Given this list of marker genes Ebag9, A830018L16Rik, Sesn1, Sppl2a, Tbc1d8b, Tex30, Aspn, Nup58, Nt5c3, Cxcl13, 5330438D12Rik, Ube2v2, Eif2s2, Ssr1, Slc7a3, Gimap5, Marchf5, C1galt1c1, Sp110, Lemd3, Ly96, Fgfbp3, Lrrc75b, Trem2, Cstdc4, Mterf2, Myo1c, Acyp2, B3galnt1, Tmem126a, Atp6ap2, Slc26a11, Gin1, Sparcl1, Ubqln2, Ptgs1, Slc35b3, Flvcr1, Pias2, Amy1, Dvl1, Fgf18, Orc6, Zfp185, Plekhs1, Casp12, Klf9, Rps6kb1, Tmem35a, Cpa3, Hnrnpdl, Arrb2, Syncrip, Mbd1, Cav1, Pik3r3, Paip1, B2m, Slc25a12, Hnrnpll, Ncl, Fndc1 (NCBI Gene Id 68807), Ric8a, Sema3g, Arl13b, Smg7, Depdc1a, Acat1, Mmrn1, Tipin, Zfp973, Tle1, Nab1 (NCBI Gene Id 17936), Sbds, Cavin2, Sdcbp, Cnih1, Pdcd10, Adamts2, Ms4a6d, Tac1, Nmb, Ifrd1, Agl, Ktn1, P4ha2, Spink2, Ppp4r1l-ps, Dixdc1, Slc35a5, Colec12, Gfpt1, Agbl3, Fap, Hdc, Slc1a3, Wfdc18, Usp16, Vegfd, Psmc6, Trappc2b, Zfp639, Pfas, Tyrobp, Mpc1, Fabp4, Vip, Ndfip2, Atrnl1, Sfxn3, Slc38a9, BC050972, Scyl3, Ptprb, Qpct, Spopl, Med21, Lhx6, Calca, Ramac, Rnf11, Serinc3, Ccdc32, Gclc, Dock11, Plgrkt, Gpr182, Pten, Hprt1, Smurf2, Cd300c2, Cftr, Smpdl3a, Ctso, Zfp318, Cast, Rnf130, Clec14a, Lrrc17, Ms4a6b, Casp4, Aoc3, Spryd7, Prkd3, Slc16a3, Eif2ak2, Prkcb, Aldh9a1, Synpr, 4833420G17Rik, Odf2l, Iars1, Zfp68, Gm16867, Fam177a, Zfp931, Ntan1, AW551984, Ogn, Ptgdr2 (NCBI Gene Id 14764), Sgce, Gbe1, Ccdc126, Rhoj, Egfr, here is a description of the gene set: Cancer cells differentiate along specific lineages that largely determine their clinical and biologic behavior. Distinct cancer phenotypes from different cells and organs likely result from unique gene expression repertoires established in the embryo and maintained after malignant transformation. We used comprehensive gene expression analysis to examine this concept in the prostate, an organ with a tractable developmental program and a high propensity for cancer. We focused on gene expression in the murine prostate rudiment at three time points during the first 48 h of exposure to androgen, which initiates proliferation and invasion of prostate epithelial buds into surrounding urogenital sinus mesenchyme. Here, we show that androgen exposure regulates genes previously implicated in prostate carcinogenesis comprising pathways for the phosphatase and tensin homolog (PTEN), fibroblast growth factor (FGF)/mitogen-activated protein kinase (MAPK), and Wnt signaling along with cellular programs regulating such 'hallmarks' of cancer as angiogenesis, apoptosis, migration and proliferation. We found statistically significant evidence for novel androgen-induced gene regulation events that establish and/or maintain prostate cell fate. These include modulation of gene expression through microRNAs, expression of specific transcription factors, and regulation of their predicted targets. By querying public gene expression databases from other tissues, we found that rather than generally characterizing androgen exposure or epithelial budding, the early prostate development program more closely resembles the program for human prostate cancer. Most importantly, early androgen-regulated genes and functional themes associated with prostate development were highly enriched in contrasts between increasingly lethal forms of prostate cancer, confirming a 'reactivation' of embryonic pathways for proliferation and invasion in prostate cancer progression. Among the genes with the most significant links to the development and cancer, we highlight coordinate induction of the transcription factor Sox9 and suppression of the proapoptotic phospholipid-binding protein Annexin A1 that link early prostate development to early prostate carcinogenesis. These results credential early prostate development as a reliable and valid model system for the investigation of genes and pathways that drive prostate cancer. species: Mus musculus from publication Schaeffer EM, Marchionni L, Huang Z, Simons B, Blackman A, Yu W, Parmigiani G, Berman DM (PMID 18794802) Genes up-regulated in the urogenital sinus (UGS) of day E16 females exposed to the androgen dihydrotestosterone for 6 h. Mouse Gene Set: SCHAEFFER_PROSTATE_DEVELOPMENT_6HR_UP